Given this list of marker genes Cbl, S100a10, Rgs1, Ets1, Tsc22d3, Emb, Il7r, Uba52, Tcf7, Ahnak, Cd7, Foxp1, Il18r1, Klf2, Jun, Zfp36l2, here is a description of the gene set: Mouse Gene Set: CUI_NK_CELL_IFNK_RESPONSE_DN Cytokines mediate cell-cell communication in the immune system and represent important therapeutic targets. A myriad of studies have highlighted their central role in immune function, yet we lack a global view of the cellular responses of each immune cell type to each cytokine. To address this gap, the authors created the Immune Dictionary, a compendium of single-cell transcriptomic profiles of more than 17 immune cell types in response to each of 86 cytokines (>1,400 cytokine-cell type combinations) in mouse lymph nodes in vivo. A cytokine-centric view of the dictionary revealed that most cytokines induce highly cell-type-specific responses. For example, the inflammatory cytokine interleukin-1β induces distinct gene programmes in almost every cell type. A cell-type-centric view of the dictionary identified more than 66 cytokine-driven cellular polarization states across immune cell types, including previously uncharacterized states such as an interleukin-18-induced polyfunctional natural killer cell state. Genes negatively differentially expressed in cell type: NK cell upon treatment with cytokine: IFN-κ in mouse lymph nodes in vivo. species: Mus musculus from publication Cui A, Huang T, Li S, Ma A, Pérez JL, Sander C, Keskin DB, Wu CJ, Fraenkel E, Hacohen N (PMID 38057668)